The following is a description of a gene set: Human Gene Set: HP_OROMANDIBULAR_DYSTONIA Oromandibular dystonia A kind of focal dystonia characterized by forceful contractions of the face, jaw, and/or tongue causing difficulty in opening and closing the mouth and often affecting chewing and speech. species: Homo sapiens, and this is the list of marker genes: SPG11, KMT2B, C19orf12, COASY, UBAP2L, THAP1, ALS2, FUS, SLC39A14 (solute carrier family 39 member 14), VPS16, ATN1, PANK2, COL6A3 (collagen type VI alpha 3 chain), TSPOAP1 (NCBI Gene Id 9256), TIMM8A, VPS13A, SIGMAR1, SLC6A3, TOR1A, SPTLC1, ANO3